Given this list of marker genes Gnpat, Awat1, Far1, Far2 (fatty acyl CoA reductase 2), Dhrs7b, Awat2, here is a description of the gene set: Wax and plasmalogen biosynthesis Mouse Gene Set: REACTOME_WAX_AND_PLASMALOGEN_BIOSYNTHESIS studied in species Mus musculus